Given this list of marker genes SUV39H2, DKC1, GEMIN6, DOK2, MAFB, SKP2, SF3B3, CCT6A, HSD17B10, ERP27, SLC19A2, PLEKHJ1, NINJ2, TTC8, DFFA, MCUR1, SCRIB, KLHL42, ATP5MC3, MIOS, TM6SF1, FOXRED1, ALAD, THOC5, COPS8, HEATR1, MRPS9, NSFL1C, TARDBP, TIAM1, RBBP7, PTCD3, TRPV2, ATG14, TMEM164, ICMT, POLR1E, HYCC1, BCS1L, TUBGCP5, POLE4, DELE1, NDUFAB1, NDUFAF4, FA2H (NCBI Gene Id 79152), COX11, RIOX1, SLC9A6, SLC18A2, GNA11, DDIAS, IPO11, DDX28, GIT2, FAM78A, PRKAR2A, TATDN2, PTPN9, CDK4, VRK1, SARS2, PLEKHO2, PEX1, ZNHIT6, TMTC4, ASL, SUMF1, TRMT12, SIK2, TCERG1, AP2A2, SLC12A6, POLR3B, KIAA0232, MICOS10, ATP11A, MRPL4, TRIM37, COPS9, ZNF559, URB2, TMEM273, ZYG11B, SAMM50, USP46, PIK3R1, RNF44, GLCE, CHPF2, NACC2, GBA2, MRPS6, TSFM (Ts translation elongation factor, mitochondrial), DCAF4, SHPRH, PHAX, PTK2, MAGOH-DT, OSGEPL1, ALG6, RLIG1, PACSIN2, PCYOX1L, GSE1, CTR9, ZNF641, CORO1A, ATP5PF, HSPA14, IMPDH1, MLXIP, TMEM223, FLVCR2, ROGDI, ADD3, MTFR2, RNF166, SGK1, RRP15, CHCHD4, IFNGR2, EPRS1, C9orf40, MTCH1, UBXN2B, GATD3, SNRNP200, FBXO21, MRI1, ARB2A, NF2, PCYOX1, ASB7, MRPL24, SCFD2, LAMTOR5, PXMP4 (NCBI Gene Id 11264), JTB, EBNA1BP2, TRMT1, SNRNP35, ST6GAL1, EXOSC5, RCAN3, POP1, ZFYVE21, TTLL1, TNRC18, ANKMY2, DNAJC11, ACOT7, TFAM, ELP1, TUBG1, MADD, CHCHD7, ARID1A, ABAT, RAD51C, PRPS2, UROD, ATMIN, NAPEPLD, EIF4EBP2, TMEM45B, COA5, ZNF319, GTF3C2, MRPS26, TMT1A, SLC25A12, IFT27, NUDT4, SPIRE1 (spire type actin nucleation factor 1), DHFR, FRMD4A (NCBI Gene Id 55691), DCAF13, TASP1, PPP4R1, ELOVL1, HMBS, CIAPIN1, STRAP, MTX3, NUDT6, DMAC2, TACO1 (translational activator of cytochrome c oxidase I), ZNF234, CEP164, POP5, GFOD1, DHX30, SKA2, COQ9, HCFC2, MAP7 (microtubule associated protein 7), RPAP2, TP53RK, AP3D1, here is a description of the gene set: Genes up-regulated in comparison of control conventional dendritic cells (cDC) at 0 h versus cDCs infected with Newcastle disease virus (NDV) at 14 h. The dendritic cell (DC) is a master regulator of immune responses. Pathogenic viruses subvert normal immune function in DCs through the expression of immune antagonists. Understanding how these antagonists interact with the host immune system requires knowledge of the underlying genetic regulatory network that operates during an uninhibited antiviral response. In order to isolate and identify this network, we studied DCs infected with Newcastle Disease Virus (NDV), which is able to stimulate innate immunity and DC maturation through activation of RIG-I signaling, but lacks the ability to evade the human interferon response. To analyze this experimental model, we developed a new approach integrating genome-wide expression kinetics and time-dependent promoter analysis. We found that the genetic program underlying the antiviral cell state transition during the first 18-hours post-infection could be explained by a single regulatory network. Gene expression changes were driven by a step-wise multi-factor cascading control mechanism, where the specific transcription factors controlling expression changed over time. Within this network, most individual genes are regulated by multiple factors, indicating robustness against virus-encoded immune evasion genes. In addition to effectively recapitulating current biological knowledge, we predicted, and validated experimentally, antiviral roles for several novel transcription factors. More generally, our results show how a genetic program can be temporally controlled through a single regulatory network to achieve the large-scale genetic reprogramming characteristic of cell state transitions. from publication Zaslavsky E, Hershberg U, Seto J, Pham AM, Marquez S, Duke JL, Wetmur JG, Tenoever BR, Sealfon SC, Kleinstein SH (PMID 20164420) studied in species Homo sapiens Human Gene Set: GSE18791_CTRL_VS_NEWCASTLE_VIRUS_DC_14H_UP